Given this list of marker genes IPO8, PIEZO2, PRKACB, COL1A2, CHST14, MAB21L2, DSE, AEBP1, LMNA, BPNT2, AHDC1, COL1A1, COL5A2, SCARF2, RYR1, here is a description of the gene set: species: Homo sapiens Recurrent joint dislocation Dislocation of a given joint repeated times. Human Gene Set: HP_RECURRENT_JOINT_DISLOCATION